The following is a description of a gene set: The hydroxylation of peptidyl-lysine to form peptidyl-hydroxylysine. studied in species Mus musculus Mouse Gene Set: GOBP_PEPTIDYL_LYSINE_HYDROXYLATION, and this is the list of marker genes: Plod3 (procollagen-lysine, 2-oxoglutarate 5-dioxygenase 3), Fkbp10, Jmjd6, P3h4, Plod1, P3h3, Vps33b, Plod2, Vipas39